The following is a description of a gene set: studied in species Mus musculus Mouse Gene Set: GOCC_HOST_CELL_PART Any constituent part of a host cell. The host is defined as the larger of the organisms involved in a symbiotic interaction., and this is the list of marker genes: Iigp1, Gbp2b, Gbp2, Gbp6, Gbp3, Gbp7, Gbp9